The following is a description of a gene set: studied in species Homo sapiens Human Gene Set: MODULE_278 Ubiquitin ligases., and this is the list of marker genes: ASNS, CTPS1, MTHFD1, GCLC, UBE2G1, UBE2S, MTHFS, GCLM, PRPS2, UBE2V1, PCCB, UBE2E1, GMPS, CDC34, UBE2K, UBE2D1, UBE2A, GSS, UBE2M, PAICS, UBE2D2, HERC2, UBR5, WWP2, UBE2V2, UBE3C, UBE2C, GART, UBE2H, CAD, TRIP12, UBE2N, GATB, FBXO21